The following is a description of a gene set: A dialeptic seizure is a type of seizure characterized predominantly by reduced responsiveness or awareness and with subsequent at least partial amnesia of the event. studied in species Homo sapiens Dialeptic seizure Human Gene Set: HP_DIALEPTIC_SEIZURE, and this is the list of marker genes: DPM1 (NCBI Gene Id 8813), PAFAH1B1, GRIN1, KDM6A, CAMK2A, VPS35L, RORB (RAR related orphan receptor B), GNAO1, RFX7, CACNA1D, RERE, RNU4ATAC, GRIN2B, CAPRIN1, AFG2B, ATP6V0A1, MTHFR, CASR, KPTN, JRK (NCBI Gene Id 8629), TRPM3, UBE3A, MACF1, DYRK1A, GABRA1, HCN1, SCN8A, RAI1, ADNP, PIGM, ACSF3, ARX, SUPT16H, SCN2A, PAK3, SLC35A3, FBXO28, TUBB3, ADGRG1, NEDD4L, FRRS1L, DNM1L, NGLY1, GABRD, ASAH1, PIGA, EZH2, RNU12, PCDH19, ALDH5A1, STXBP1, TRIM8, GABRB3, KCNQ3, PRMT7, TBC1D24, CDK13, PPP3CA, SLC25A22, EPM2A, PIGT, PLCB1, MAPK10, KCNMA1, PPOX, SLC12A5 (solute carrier family 12 member 5), GABRA3, SCN1A (sodium voltage-gated channel alpha subunit 1), CLPB, FMN2, SLC31A1, TSC1, CPA6, GNAI1, WAC, SCN9A, CACNA1A, CSTB, AGO1, MTOR, EFHC1, GJC2, ATP1A3, GNB1, ALDH4A1, ATP6V0C, DMXL2, GDI1, GABRG2, FIG4, GPAA1, FGFR3, CNTN2, SZT2, TBK1, CRELD1, SPTAN1, NEUROD2, CACNA1H, DPM3, AFF3, PIGQ, POGZ (pogo transposable element derived with ZNF domain), HNRNPK, CNOT1, ALDH7A1, PTEN, HNRNPU, KCNT1, SON, LAMA2, TLR3, NBEA, ATP6V1B2, DOCK7, FGF13, PGAP1, HNRNPC, STX1B, ADPRS, GRM7, GPT2, DHDDS, CACNA2D1, GRIK2, GATAD2B, NFKB2, COQ4, KCNB1, KMT2D, NPRL2, PUM1, RELN, DEPDC5, SLC2A1, SLC32A1, CLCN2, CRIPT, NPRL3, CNTNAP2, TRAF3, MYT1L, PHGDH, TUBA1A, STRADA, PNPLA8, GAL, SIK1, GNB2, ZFX, LAMC3, GLUL, CIC, KIF4A, VPS11, KCNQ2, ARHGEF9, PGAP2, NUBPL, FZR1, TICAM1, SMPD1, KCNC2, GJA8, PLPBP (NCBI Gene Id 11212), DHFR, TGFB1, NHLRC1, AFG2A, LGI4, AP2M1, YWHAG, PPFIBP1, UNC93B1, TRMT10A, CUX2, TANGO2, EIF4A2 (NCBI Gene Id 63124), ADGRV1, ZEB2 (zinc finger E-box binding homeobox 2), KCNQ5, LGI1, CLN8, DNM1 (dynamin 1), SATB1, CASK, NADK2, ATXN10, NEXMIF, PPP2CA, FAR1, FBXL4 (NCBI Gene Id 26235), SATB2, NSD1, ITPR1, PIGP, EEF1A2, EHMT1, MEGF8, PDE2A, CHD2, CEP85L, GOSR2, BRAT1 (BRCA1 associated ATM activator 1), BCKDK, MAST3, GAMT, PNKP, SMARCA2, CDKL5, CDH2, NUS1, CAMK2B, SYNGAP1, MICAL1, TSC2, GLUD1, SCN3A (NCBI Gene Id 6328), ALMS1, OTUD7A, HID1, CLCN4, CACNB4, COL3A1 (collagen type III alpha 1 chain), APC2, NTRK2, ATAD3A, ECM1, SETD1B, PRRT2, GABBR2, CNPY3, WDR26 (NCBI Gene Id 80232), OPHN1, KDM6B, CILK1, GJA5, HTT, SLC6A1, SCN1B, KCNT2, ZNFX1, SRPX2, KCNA1, GRIN2A, WWOX, KCNH5, TUBB2B, ZBTB18, LRP5, MECP2